The following is a description of a gene set: A protein complex that possesses activity that prevents or downregulates transcription. Human Gene Set: GOCC_TRANSCRIPTION_REPRESSOR_COMPLEX studied in species Homo sapiens, and this is the list of marker genes: MYC (MYC proto-oncogene, bHLH transcription factor), CTBP2, ZBTB16, GMNN, CDX2, LIN37, AKIRIN2, HDAC1 (NCBI Gene Id 3065), C1D, MEN1, DRAP1, PHF12, MDM4, HMGB1, ELANE, LIN9, CCND1, MXD1, INSM1, DDX20, GLI3, TBX15, JUND, CTNNBIP1, JUN, DR1, DEPDC1, HEY2, LIN54, LIN52, BIN1, INSM2, GFI1, SP3, N4BP2L2, GATA1, NCOR1, SDR16C5, HDAC3, ARID4A (NCBI Gene Id 5926), PRDM10, CRY2, PRDM16, ZNF224, PASD1, JAZF1, H1-0, TP53, RCOR1, MDM2, MAX, ZFPM1, CTBP1, RELB, HDAC4, TFAP4, TBL1XR1, TBL1X, ZNF350, PER2, HOXD10, MIER1, RLIM, RBBP8, ETV3, CTNNB1, HDGF, SP1, TBX18, SPEN, HOXC9, GPS2, REST, CORO2A, FOXO3, NCOR2, CBX5, RBPJ, YWHAB, SIN3A, SKI